The following is a description of a gene set: Catalysis of the reaction: NADH + ubiquinone + 5 H+(in) = NAD+ + ubiquinol + 4 H+(out). Mouse Gene Set: GOMF_NADH_DEHYDROGENASE_UBIQUINONE_ACTIVITY studied in species Mus musculus, and this is the list of marker genes: Ndufa10, Ndufs8, Ndufs1, mt-Nd2, Ndufv2, mt-Nd4l (mitochondrially encoded NADH dehydrogenase 4L), mt-Nd4, Ndufs2, Ndufs7, Ndufs3 (NCBI Gene Id 68349), mt-Nd3, mt-Nd6, mt-Nd1, Ndufs4, mt-Nd5, Ndufv1, Ndufb7, Ndufa2